Given this list of marker genes DIAPH1, RUFY3, TXLNA, CUTALP, CATSPERB, MPHOSPH10P1, TPT1P15, HMGB1P11, GBA1, RPL21P77, SSBP1, HES1, PLPP5, ADAP2, WEE2-AS1, MED12, NECTIN1, PAK3, TAGAP-AS1, LOXL1, RNU6-784P, LINC02930, CERCAM, FKBP5, TEFM, LOXL1-AS1, ZNF778, RAI14, DNAJC16, MVP-DT, BCR, MEGF10, LINC00926, ZNF540, FOXN3, CYP4V2, SMC6, NPR3, MRPL44, MTCO3P12, CASP9, CNDP1, LINC01931, ZNF461, TMEM131, CPD, LINC02769, KDM4C, ANK2, OAT, MIR1273C, ERCC2, MVP, QRICH1, LINC02934, ZBTB22, RPS10P27, USP32, here is a description of the gene set: from publication Yevshin I, Sharipov R, Kolmykov S, Kondrakhin Y, Kolpakov F (PMID 30445619) Human Gene Set: ZNF586_TARGET_GENES Genes containing one or more binding sites for (ZNF586) in their promoter regions (TSS -1000,+100 bp) as identified by GTRD version 20.06 ChIP-seq harmonization. species: Homo sapiens